Given this list of marker genes CTTN, PIDD1, PRKAG2, ABCG1, ALOX15B, PNRC1, FBN2, BTN3A3, EML2, LRP5, CD70, CPT1B, N4BP2L2, PSEN2, LGALS7, STC2, GUSBP14, SLC39A7, LAPTM5, IL15, ZNF184, ASNS, OBSL1, EGFR, TXNIP, CELSR2, CRIP2, CRELD1, HERC1, GCLC, TCEA2, ZP3, GABARAPL1, EPHB3, CEP152, CD44, CADM4, NR1D1 (NCBI Gene Id 9572), ALDH6A1, RNASE4, TP53TG1, PAMR1, NUPR1, THSD4, CYP4F11, HCFC1R1, INPP5D, GFPT1, MMP28, BBLN (bublin coiled coil protein), ATF3, GPC1, AKR1B10, CD55, P3H1, MDM2, HCP5, PAN2, CCNA1, TSC22D3, YIPF2, EFS, SEMA3F, TMT1A (thiol methyltransferase 1A), PER2, IGFBP2, PGM3, LINC00115, NINJ1, KLHL24, SENP6, CDKN1B, TMEM187, SDHAP3, EFEMP2, FAM117A, C1QL1, PER1, SEC24D, CTH, ZMAT3, AKR1C3, PRSS16, HSPA13, FTL, ABHD4, CSRP2, GPX3, GOLGA2, GID4, KHNYN, BTG2, WIPI1, THEMIS2, CYP4F3, PCK2, LEPR, ZNF451, LHX6, DLGAP4, EPHX1, ZMYM2, BCL6, RRAS, PPFIBP1, ZBTB16, PHGDH, DNAJB9, H1-10, MAGED2, LTB, AKR1C1, APOE, DBP, IL1RAP, ANG, PDE4DIP, PRSS8, PTGS1, BLNK, CYP1B1, KDELR3, MIR3648-1, TMEM214, MST1 (NCBI Gene Id 4485), PRKCA, DIDO1, ZNF516, CHAC1, FBXO2, MAGED1, BHLHE41, GDF15, CALML4, ZNF750, KCNMA1, KLF9, METTL25B, TGFB1, ZNF226, NR1D2, here is a description of the gene set: species: Homo sapiens from publication Onder TT, Gupta PB, Mani SA, Yang J, Lander ES, Weinberg RA (PMID 18483246) Genes up-regulated in HMLE cells (mmortalized nontransformed mammary epithelial) by expression of a dominant-negative form of E-cadhedrin (CDH1). Loss of the epithelial adhesion molecule E-cadherin is thought to enable metastasis by disrupting intercellular contacts-an early step in metastatic dissemination. To further investigate the molecular basis of this notion, we use two methods to inhibit E-cadherin function that distinguish between E-cadherin's cell-cell adhesion and intracellular signaling functions. Whereas the disruption of cell-cell contacts alone does not enable metastasis, the loss of E-cadherin protein does, through induction of an epithelial-to-mesenchymal transition, invasiveness, and anoikis resistance. We find the E-cadherin binding partner beta-catenin to be necessary, but not sufficient, for induction of these phenotypes. In addition, gene expression analysis shows that E-cadherin loss results in the induction of multiple transcription factors, at least one of which, Twist, is necessary for E-cadherin loss-induced metastasis. These findings indicate that E-cadherin loss in tumors contributes to metastatic dissemination by inducing wide-ranging transcriptional and functional changes. Human Gene Set: ONDER_CDH1_TARGETS_1_UP